The following is a description of a gene set: Any process that modulates the frequency, rate or extent of relaxation of cardiac muscle. Human Gene Set: GOBP_REGULATION_OF_RELAXATION_OF_CARDIAC_MUSCLE studied in species Homo sapiens, and this is the list of marker genes: PDE4B, CHGA, PLN, HRC, PDE4D, CAMK2D